Given this list of marker genes Iqgap1, Vangl1, Pard6a, Txnl1, Wwp2, Sptan1, Cltc, Rhou, Arhgap31, Depdc1b, Pak4, Sptbn1, Myo6, Pak3, Arhgap30, Usp9x, Dlg5, Git2, Pik3r2, Itsn2, Wdr6, Arhgef7, Dst, Pak2, Hgs, Nck1, Pik3r1, Epha2, Peak1, Cdc42, Stam, Arhgef6, Git1 (NCBI Gene Id 63992), Stam2, Ptk2b, Pak1, Srgap2, Grb2, Nck2, here is a description of the gene set: Mouse Gene Set: REACTOME_RHOU_GTPASE_CYCLE studied in species Mus musculus RHOU GTPase cycle